Given this list of marker genes ST6GALNAC5, COL4A3, FILIP1, ADIRF, SUSD3 (NCBI Gene Id 203328), MSLN, ICAM4, here is a description of the gene set: from publication He P, Lim K, Sun D, Pett JP, Jeng Q, Polanski K, Dong Z, Bolt L, Richardson L, Mamanova L, Dabrowska M, Wilbrey-Clark A, Madissoon E, Tuong ZK, Dann E, Suo C, Goh I, Yoshida M, Nikolić MZ, Janes SM, He X, Barker RA, Teichmann SA, Marioni JC, Meyer KB, Rawlins EL (PMID 36493756) species: Homo sapiens Late stalk Human Gene Set: HE_LIM_SUN_FETAL_LUNG_C1_LATE_STALK_CELL